The following is a description of a gene set: species: Homo sapiens Metals are necessary for all forms of life including microorganisms, evidenced by the fact that metal cations are constituents of approximately 40% of all proteins crystallized to date (Waldron KJ et al. 2009; Foster AW et al. 2014; Guengerich FP 2014, 2015). The ability of microorganisms to maintain the intracellular metal quota is essential and allows microorganisms to adapt to a variety of environments. Accordingly, the ability of the host to control metal quota at inflammation sites can influence host-pathogen interactions. The host may restrict microbial growth either by excluding essential metals from the microbes, by delivery of excess metals to cause toxicity, or by complexing metals in microorganisms (Becker KW & Skaar EP 2014). Reactome Pathway: Metal sequestration by antimicrobial proteins part of: Antimicrobial peptides, and this is the list of marker genes: S100A9, LCN2, LTF, S100A8, S100A7A, S100A7 (NCBI Gene Id 6278)